The following is a description of a gene set: Genes positively differentially expressed in cell type: Treg upon treatment with cytokine: IL-1α in mouse lymph nodes in vivo. studied in species Mus musculus from publication Cui A, Huang T, Li S, Ma A, Pérez JL, Sander C, Keskin DB, Wu CJ, Fraenkel E, Hacohen N (PMID 38057668) Cytokines mediate cell-cell communication in the immune system and represent important therapeutic targets. A myriad of studies have highlighted their central role in immune function, yet we lack a global view of the cellular responses of each immune cell type to each cytokine. To address this gap, the authors created the Immune Dictionary, a compendium of single-cell transcriptomic profiles of more than 17 immune cell types in response to each of 86 cytokines (>1,400 cytokine-cell type combinations) in mouse lymph nodes in vivo. A cytokine-centric view of the dictionary revealed that most cytokines induce highly cell-type-specific responses. For example, the inflammatory cytokine interleukin-1β induces distinct gene programmes in almost every cell type. A cell-type-centric view of the dictionary identified more than 66 cytokine-driven cellular polarization states across immune cell types, including previously uncharacterized states such as an interleukin-18-induced polyfunctional natural killer cell state. Mouse Gene Set: CUI_TREG_IL1A_RESPONSE_UP, and this is the list of marker genes: Crybg1 (NCBI Gene Id 215965), Arid5b, Donson, Atp9b, Mllt6, Gpr18, Rapgef6, Gapdh, Riok1, Arap2, Dgat1, Ppp1r16b, Pja1, Gltp, Prkch, Satb1, Gpr65, Ssh2, Mdh1, Itgb8, Gadd45b, Tspan13, Wnk1, Tut4, Foxp3, Kbtbd11, Zbp1, Ccr7, Neurl3, Ramp3 (receptor (calcitonin) activity modifying protein 3), Atp1a1, Ptpn1, H2az1, Nup98, Crlf2, Tnfrsf9, Serpinb6b, Atp5f1d, Syngr2, Odc1, Pdcd1, Cep120, Sdf4, Hif1a, Gbp5, Arid5a, Hopx, Rnf157, Stat5a, Il7r, Mif4gd, Ldha, Il6st, Cebpb, Nfkbia, Fth1, Gramd2b, Il21r, Cd2, Vps37b, Phlpp1, Gimap3, Vamp4, Zfp281, Rhoc, Gpx4, H2-K1, Socs3, Eif5a, Pkm, Zfp36l2, Prps1, Ubald2, Zfp1, Tnfrsf4, Gbp3, Apaf1, Chp1, Lamp2, Samhd1, Rpap3, Prpf8, Ifngr1, Slc25a3, Ubl5, Sipa1l1, Por (NCBI Gene Id 18984), Cipc, Sbno2 (strawberry notch 2), Emd, Fam117b, Pcgf5, Srgn, Eif1, Cd53, Tnfrsf18, Eeig1, Mt1, Isy1, Id2, Il2rb, Slc25a51, Zeb1, Ubac2, Socs1, Ftl1, Emb, Ostf1, Mxd1, Gbp2, Ier5l, B2m, Ppa1, Stx11, Etf1, Atp2b4, Vgll4, Rbm3, Rrp1b, Parp9, Slc66a2, Snx18, Pnp, Bmyc, Sla, Tspan5, Chmp4b, Elovl6, Stk24, Madd, Samsn1, Stat3, Tnfaip3, Ptpn22, C1qtnf12, Stat5b, Rgs2, Batf, Gpr146, Gadd45g, Ly6a, Arpc3, Park7, Slc48a1, Akt2, Grk6, Apobec3, Actg1, Skap2, Itpk1, Pde4d, Jak2, Ndrg3, Tmem123, Mpc1, Epb41, Cytip, Grb2, Ctla4, Malt1, Napa, Birc3, Slc41a1, Fosl2, Camk4, Stat4, Ube2j2, Vcf2, P2ry10, Fam107b, Il4ra, Myl12b, Sik3, Dennd4a, Itgav (NCBI Gene Id 76358), Serinc3, Nabp1, Mknk2, Got1, Ttc39c, Egln2, Zc3h12d, Flot1, Crem, Trib2, Mlec, Nop53, Cblb, Bcl3, Rnf19a, Rab10